The following is a description of a gene set: Absence or underdevelopment of the urinary bladder. Human Gene Set: HP_APLASIA_HYPOPLASIA_OF_THE_BLADDER species: Homo sapiens Aplasia/Hypoplasia of the bladder, and this is the list of marker genes: ITGB4, LAMC2, CC2D2A, LAMB3, LAMA3, MED12, ALG9, FREM2, GRIP1 (glutamate receptor interacting protein 1), MBTPS2, PLEC, MKS1, ITGA6, WNT4 (Wnt family member 4), CCNQ, ROBO1